The following is a description of a gene set: studied in species Homo sapiens Human Gene Set: GOBP_NEGATIVE_REGULATION_OF_SECRETION Any process that stops, prevents, or reduces the frequency, rate or extent of the controlled release of a substance from a cell or a tissue., and this is the list of marker genes: NEUROG1, INS, ABAT, KCNJ11, STK39, JAGN1, TACR2, IL11 (interleukin 11), IL1B, FCGR2B (Fc gamma receptor IIb), ADTRP, PLA2R1, FRMD4A, WNK1, RAB11FIP1, VAMP3, RAP1A, VSNL1, ADA, TNF, MIR199A1, DRD2, FAM3D, SERGEF, F2R, HMGCR, FKBP1B, APOE, GRM7, STXBP6 (NCBI Gene Id 29091), ADRA2A, SYTL4, MIR30C1, IRS1, RHBDF2, GNAI2, BMP8A, F2RL1, ADIPOQ, NPSR1, RSAD2, NPY2R, DRD3, ADRA2C, CYP4F2, IDH2, MIR146A, GNAO1, IL12A, ACVR1C, NR1H3, CD74, BCR, PDE8B, MIR19B1, MIR766, WNK3, VPS4B, C9orf72, RAB11FIP3, GGCX, NCKAP1L, LIF (LIF interleukin 6 family cytokine), TRH, MIR19A, IL12B, GNAI1, KLF7, SIRT4, HADH, MIDN, DPH3, GHRL, MTNR1B, NOTCH1, ANXA1, ADRA2B, RAP1BL, DCANP1, CRY2, PRKG1 (NCBI Gene Id 5592), GNAZ, BRAF, KCNB1, CCR2, WDR41 (NCBI Gene Id 55255), CARTPT, TNFRSF1B, FOXO1, NDUFAF2, CRY1, CCN3, INHA, PRKN, CBARP, ERP29, PSMD9 (proteasome 26S subunit, non-ATPase 9), FOXF1, ENY2 (NCBI Gene Id 56943), GHSR, SYT11, FGF23, IL1RAPL1, FMR1, NPVF, CDK5, TSPO, UCP2, RAP1B, PFKL, CRH, OSM, FFAR4, NRG1, REST, MIR93, PTPN11, GABBR1, NPFF, LEP, ADORA1, EDN1 (NCBI Gene Id 1906), P2RY1, SNCA, CRHBP (NCBI Gene Id 1393), EGF, SPX, IL13RA2, VAMP8, NMB, CYP51A1, NMU, HLA-F, CD200, KCNK9, NEO1, TIFAB, CD300A, OPRM1, RABGEF1, CHGA, MIR33A, OPRK1 (NCBI Gene Id 4986), STXBP3, TFF2, HTR1B, RAB33B, TNFRSF1A, LILRB1, PIM3, ERBB3, CEACAM1, FFAR2, SREBF1, SLC30A1 (NCBI Gene Id 7779), PTGER3, RAB7A, GJA1, UCN, ACSL4, ASIC1, INHBB, SPI1, CD84, DRD4, PNKD, NF1, INHBA, ATP9A, LGALS9, SCT, WNK4 (WNK lysine deficient protein kinase 4), RAB11FIP5, SYT4, MIR29B1, RHBDF1, NPY5R, SMCR8, ABCC8